Given this list of marker genes NOXA1, DVL1, DVL3, NOX1, JUN, WNT5A, FZD7, CYBA, NOXO1, DVL2, MAPK8, RAC1, here is a description of the gene set: Reactome Pathway: WNT5:FZD7-mediated leishmania damping studied in species Homo sapiens Wnt-5a (WNT5) is known for being a highly specific regulated gene in response to microbial infection including leishmaniasis, where it seems to be involve in mechanisms that dampen the parasite load within main host macrophages. In addition, WNT5 is a highly responsive gene in human macrophages present in chronic diseases such as rheumatoid arthritis, cancer, atherosclerosis and obesity (Ouchi et al. 2010 & Ljungberg et al. 2019).<br><br>Frizzled-7 (FZD7) acts as a receptor of WNT5 which, upon binding, is implicated in the initiation of the non-canonical WNT pathway that ends up in the re-accommodation of the cytoskeleton to allow a process called planar cell polarity (PCP). The activation of the WNT5:FZD7 non-canonical signalling cascade that drives PCP is being studied for its involvement in inflammatory responses. Treatment of RAW264.7 macrophages with recombinant Wnt5a induced NADPH oxidase-mediated ROS production, which has been suggested to contribute to the macrophage control of L. donovani. Consequently, detailed understanding of how WNT signaling network defines host responses to infection could be important to identify potential targets. part of: Killing mechanisms